The following is a description of a gene set: from publication Chen Y, Wang X (PMID 31504780) Mouse Gene Set: MIR_126B_5P Genes predicted to be targets of miRBase v22 microRNA mmu_miR_126b_5p in miRDB v6.0 with MirTarget v4 prediction scores > 80 (high confidence targets). studied in species Mus musculus, and this is the list of marker genes: Rsbn1l, Rasl10a, Errfi1, Ccdc85a, Dcaf7 (NCBI Gene Id 97751), Pcdha6, Enpp1, Ubp1, Ntng1, Mrpl51, Pcdha12, Cav2, Cxcl10, Cntn3, Wac, Ruvbl1, Irf2bpl, Ankrd1, Lars1, Ppm1k, Ppp1r10, Stoml2, Trim9, Gabra4, Ube2d3, Mageb5b, Ngdn, Rnpc3, Hoxd1, Mapkap1, Pde3b, Mtss2, Tbrg1, Pnpo, Gm3604, Penk, Vps72, Arl8b, Lrrcc1, Zc3h7a, Hspe1, Sec63, Khdrbs1, Cenpk, Uba3, Sclt1, Slc66a3, Klhl9, Ccdc121rt1, Ccdc68, Dusp14 (NCBI Gene Id 70140), Gm4894, Edem1 (NCBI Gene Id 232324), Tomm20l, Phf1, Dgkb, Arih1, Lsm8, Scai, Kdm5c, Rps6ka6, Kif3b, Rarres1, Plaat1, Man2a1, 1700017N19Rik, Phlpp1, Zfp944, Plekhg1, Mettl25, Arpp21, Mras, Lbhd1, Birc6, Grhl3, Enpp2, Ackr4, Mrpl39, Bmal1, Aqp8, Rprml (reprimo-like), Gpr176, Dnajc8, Shmt2, Hsd11b1, Tmem64, Sarnp, Map4, Kifc5b, Pkia, Tmem167, Zfp207 (zinc finger protein 207), Xcl1, Zfp935, Klf12, Rab27b, Ufl1, Shisal1, Dcaf12l1, Krtap3-1, Zeb2, Lgmn, Map7d2, Slu7, Zfp507, Washc4, Cnot2, Itgbl1, Ddx46, Rgs5, Vti1b, Gm5141, 1810009A15Rik, Ide, Arrdc4, A830018L16Rik, Csrnp2, Nr0b2, AA467197, Cryab, Pcdha5, Clip1, C8b, Igdcc4, Bend5, Ssr2, Ptges2, Grk4, Ppargc1a, Galc, Gria4, Lpin1, Lin9, Grm5, Cip2a, Arhgap17, Cox6b1, Araf, Zc3h13, Plxnd1, Adamts1, Herc4, Stx16, Ddx54, Nedd4l, Zfp1008, Pag1, Erg28, Bltp1, Garnl3, Tmem70, Map4k4, Cdc37l1, Ccdc102a, Btg2, Pgm2l1 (NCBI Gene Id 70974), Trio, Fam114a2, Fat1, Elavl4, Pam, Elavl1 (NCBI Gene Id 97501), Rexo1, Cxxc1, Arl1, Alx3, Sptbn1, Golph3l, Ranbp6, Rag2, Grip2, Clec2h, Prpf8, Ptprb, Hdac1, Wasf1, Stra6, Pcdha7, Cpne2, Sorbs1, Lgr5, Or5m3b, Spryd7, Tmem200a, Amdhd1, Stum, Nus1, Mmp10, Sema6a, Pigt, D030056L22Rik, Ednrb, Rnf13, Slc25a37, Pip5k1c, Amigo3, Polr3e (polymerase (RNA) III (DNA directed) polypeptide E), Slc27a3, Csnk1d, Pkdcc, Zfp148, Tm7sf3, Homer1, AW554918, Ipo4, Csmd2, Fermt2, Tmprss11a, Tex14, Casz1, Ralyl, Tmem107, Agtr2 (NCBI Gene Id 11609), Fgfr2, Ppp2r5c, Thsd7a, Tdp2, Chfr, Rbl1, Mrgprb1, Npepps, Cdk2ap1, Lgals3, Poglut2, Etfa, Hspa4l, Tmem8b, Stard3nl, Coa3, Mad2l1, Pcp4, Wwp1, Snx2, Synpo2, Zfp992, Bcl3, Nde1, Ints11, Gaa, Tafazzin, Dcbld1, Pcdhac1 (NCBI Gene Id 353236), Chsy3, Rbm20, Tm9sf3, Znfx1, Cops5, Ss18l2, Gpr180, Tasp1, Camk1, Col23a1, Hlf, Unc5c, Gnb1, Adck1, Gspt1 (G1 to S phase transition 1), Pcdha4, Clic1, Zfp229 (zinc finger protein 229), Idh3a, Ssrp1, Ikzf5, Ptges3, Adam15, Cntn4, Tnip2, Svbp, Gle1, Lpar4, Zfp967, Cntn1, Atox1, Sox10, Cwc25, Krtcap3, Nck2, Celf4, Npas2, Gngt1, Capn12, Ubfd1, Gprin1, Dram1, Ciao1, Hmgb2, Shisa2, Pcdh8, Hps5, Col3a1, Unc50, Hvcn1, Clec4e, Lsm7, Cwc15, Pim2, Cebpz, Creld2, Caap1, Pcdhac2, Wdr35, Bcas1, Rtf1, Rp1 (NCBI Gene Id 19888), Sema3f, Scn1a, Manba, Map2k1, Fam186b, Mapk8ip3, Ppp1r15b, Mab21l2, Slc39a12, Spty2d1, Tlk2, Gvin1, Psma3, Aph1c, Ezh1, Sri, Dnase1l3, Foxc1, Taok1, Grm4, Atg10, Hhipl2, Scarb2, Slc5a1, Ppp1r1b, Cdk8, Azi2, Dtx3l, Clp1, Acsl1, Leprot, Jun, Septin7, Ppp3ca, Smarca5, Csnk1e, Rbm10 (NCBI Gene Id 260306), Specc1l, Med11, Dnal1, Shisa5 (shisa family member 5), Rprd2 (NCBI Gene Id 99938), Pnpla8, Iqck, Safb, Pcgf2, Entpd2, Rnft1, Miga1, Ttll7, Kif11, Cyp7b1, Lair1, Lsp1, Fam169a, Ube4a, Shank3, Il17a, Armc10, Dmp1, Rab6a, Zc2hc1a, Lox, Alg9, Sfrp2 (NCBI Gene Id 99743), Isg20, Cnnm4, Rffl, Kcnh5, Zfp354c, Dip2a, Taf1, Tnfaip8l3, Gm15455, Tubg1, Traf4, Siah2, Gvin2, Pde1c, Hectd2, Hephl1, Amotl1, Sft2d1, Rchy1, Kcnn4, Tfap2c, Fmo5, Zdhhc18, Fbxo27, Ica1, Cimip2b, Lef1, Kdm2a, Dnajc3, Zfp936, Ncapd3, Gabra1, Slc35g1, Garre1, Creb1, Pla2g12b, Eif3j2, Appl2, Pex14, Edn2, Shd, Fyn, Krtap4-1, Crh, Prpf39, Ptgr3, Tcfl5, Wdr83, Rtn2, Selenon, Ap4e1, Neurod1, Fgf12, Pcf11, Rap2c, Golm2, Agl, Fbxo6, Tmem200c, Pcdha11, Eif4e, Vipas39, Rrad, Baz1b, Tmbim1, Dnajc19, Psmb9, Pla2g10, Col4a1, Utp18, Rnf38, Trnt1, Snrnp200, Cadm1, Mtmr6, Ddit4 (NCBI Gene Id 74747), Pgam5, Ribc1, Ankrd40, Ino80c, Pomt2, Ppp4r2, Ltk, Twsg1, Dhx36 (NCBI Gene Id 99809), Map4k5, Chd1, Becn1, Lhx6, Arpc3, Ube2d2a, Syndig1l, Slc44a5, Ctdp1 (NCBI Gene Id 67655), Zbtb41, Btrc, Ston2, Cep43, Hesx1, Relch, Abhd13, 2010315B03Rik, Gucy1a1, Pcdha9, Runx1t1, Mgp, Irak1, Spata7, Fsd1l, Trpc5, Mrps36, Mrfap1, Prkx, Spsb4, Depdc7, Bbx (bobby sox HMG box containing), Ap1s2, Elp5 (NCBI Gene Id 54351), Pdk4, Pfkfb2, Rab33b, Tmem237, Brms1l, Srp72, Hspd1, Slc7a8, Col11a1, Kdelr3, Itpr1, Zbtb45, Ccdc127, Tma7, Abca15, Rnf146, Mpzl2, Gpr34, Mgrn1, Hoxa1, Dio2, Prr3, Car6, Ino80d, Leo1, Ppp4r3b, Dynlrb2 (dynein light chain roadblock-type 2), Fhip1b, Far1, Edem3, Tmeff2, Zic3, Fzd3, Nfyb, Tmem79 (transmembrane protein 79), Tmem265, Crtc1, Epha10, Ripply2, Ppp2r2a, Cad, Ctcf, Lrfn4, Dbndd2, Cpsf7, Rnf138 (NCBI Gene Id 80618), Ybx1, Cobll1, Ihh, Actr3b, Ccne1, Myzap, Lsm11, Zfp280c, Pcdha3, Scaf11, Ackr3, Rab11a, Rps3, Unc80, Tax1bp1, Fam199x, Slc38a9, Sirpa (signal-regulatory protein alpha), Eprs1, Ube2l3, Ppat, Slc16a4, Nob1, Lrrk2, Plcxd2, Cib1, Pcdha10, Tap1, Slc25a46, Mat2b, AI593442, Ankra2, Med14, Thoc7, Magoh, Ids, Lamc1, Tsc22d2, Eif3j1, Ceacam12, Ubl3, Tfrc, Adamts17, Arl5a, Zfp511, Zfp654, Trp53bp2, Dclk1, Rgs2, Cdh12, Slc30a9, Pcdha2, Tuft1, Dst, Ubn2, Il17f, Kras, Cog5, Gpm6a, Gmfb, Rxrg, Atxn1, Parp2, Gm10778, Tmem196, Zfp758, Dnali1, Coq9, Pcdha1, Tfap2b, Mrps18a, Rpl15, Eya1, Spin4, F2r, Mgat4b, Hnrnph3, Cacnb4, Creb5, Eomes, Pdlim5, Tyw1, Tpr, Kcnj4, Dbr1, Anks1b, Cdh20, Cntrob, Slc39a2, Ptprf, Trappc12, Chchd3, Srsf12, Upf1, Ankrd12, Polk, Smug1, Jmjd6, Dab2ip, Selenoi, Pcdha8, Uvssa, Plk4, Tctn2, Syncrip, Gje1, Ppp6r3, Qpct, Vip (NCBI Gene Id 22353), Tmem33, Eef2k, Rsf1, Spaca3, Ciao2b, Plppr2, Plat, Gtf2h4, Lama2, Bzw1, Colec12, Naaladl2, P2ry10, Osbpl3, Snx1, Nampt, Pdpk1, Tmem163